Given this list of marker genes PTEN, BMPR1A, CP (ceruloplasmin), GREM1, DDX41, TBXAS1, here is a description of the gene set: studied in species Homo sapiens Refractory anemia Human Gene Set: HP_REFRACTORY_ANEMIA